Given this list of marker genes MIR372, MBLAC1, WNT10B, PLCB1, USP2, PTPN11, DDR2, MIR520H, CCND2, SMOC2, SKA3, EIF4E, CUL3, ANKRD17, ANAPC5, STAT5A, TERT, CCNB1, CCDC57, RAB11A, STIL, POLDIP2, EIF4G1, RCC2, USP22, MIR221, CDK4, CDC6, SHB, CDC25B, ESPL1, AKT1, NKX3-1 (NCBI Gene Id 4824), EGFR, ASNS, APP, ADAMTS1, AURKA, RPTOR, BRD4, MAD2L1BP, STAT5B, CDC23, MIR222, BIRC5, CUL4B, MIR495, FGF10, SKA1, ADAM17, PRAP1, SIN3A, TTL, HSF1, RRM2B, CPSF3, MIR520A, CDK1, KCNA5 (potassium voltage-gated channel subfamily A member 5), SPHK1, PPP1R10, CDC16, DUSP3, FOXA1, MIR214, CDK10, CDCA5 (NCBI Gene Id 256676), RAD51B, UBE2C, MIR515-1, CDC7, MDM2, CCND1, MIR519D, SASS6, CDC20, TAL1, RDX, PLRG1, RB1, FBXO5, CCND3, TMOD3, MEPCE, FGFR1, DBF4B, PTENP1-AS, LSM10, CDC25A, DDX3X, PKN2, RAD51C, RPS6KB1 (ribosomal protein S6 kinase B1), NSMCE2 (NCBI Gene Id 286053), MAD1L1, CENPJ (NCBI Gene Id 55835), DTL, TGFB1, AIF1, RGCC, PHOX2B, KMT2E, NEUROG1, PRKCA, CYP1A1, LSM11, ANAPC7, EIF4EBP1 (NCBI Gene Id 1978), PBX1, CDC25C, STOX1, ANAPC11, DYNLT3, ABL1 (NCBI Gene Id 25), PAFAH1B1, BRCA2, TFDP1, MTBP, HSPA2, RRM2, MIR29A, CCNE2, MIR208A, HES1, CCNE1, LGMN, MEIS2, UBE2E2, KLHL18, SMARCD3, CUL4A (cullin 4A), DLGAP5, ANXA1, VPS4B, RRM1, MTA3, here is a description of the gene set: species: Homo sapiens Any process that activates or increases the rate or extent of progression through the mitotic cell cycle. Human Gene Set: GOBP_POSITIVE_REGULATION_OF_MITOTIC_CELL_CYCLE